Given this list of marker genes KIRREL3, KIRREL1, IQGAP1, NCK1, MAGI2, PIK3CA, PIK3R1, ACTN1, SPTAN1, KIRREL2, WASL, PIK3R2, SPTBN1, PIK3CB, ACTN2, CASK, NPHS2, CD2AP, FYN, ACTN3, NPHS1, ACTN4, NCK2, here is a description of the gene set: Nephrin family interactions studied in species Homo sapiens Human Gene Set: REACTOME_NEPHRIN_FAMILY_INTERACTIONS